Given this list of marker genes LAMP3, LSM11, SLC25A37, SOX6, CACNA2D1, RTN4, PTPN3, SLC13A3, AHCYL2, FGF2, UBFD1, NR2C2, PPP1R11, SUMO3, TBP, SLC12A2, SGK1, RPS6KA6, PTH, NAPG, PTPRD, ETNK1, RECK, ZCCHC2, TMEM245, RBM12, CHAC1, CD3E, ZNF449, MAP3K9, PISD, MTFR1L, BZW1, ARHGAP32, TGFBR3, MYLK, SYPL1, CYB561A3 (cytochrome b561 family member A3), P3H2, EPHB2, PHF19, NRBP1, PDK4, TUBA4A, SNX16, C1QL3, COL12A1, SUZ12, RAB11FIP2, LUZP1, CHPT1, ABL2, CCND2, LRIG2, YWHAH, FLT3, SSR1, SLC39A10, CCDC83, UNC13A, WNK3, SMURF2, RNF217, SPTLC1, LITAF, RAD23B, BCL11B, RORA, PAFAH1B2, HOXA10, PDE3B, KIF5B, PLRG1, ZC2HC1A, MYEF2, EYA1, FAM110C, ATXN7L3B, MAP7, SLC2A3, FAM81A, FAM91A1, RASGEF1B, PPM1E, EZH1, SKI, MAN2A2, FAM133B, ANKS1A, KIF5C, USP25 (ubiquitin specific peptidase 25), C2orf72, MIDEAS, TCAIM, CMC4, KIF3B, PTPN4, OMG, SIRT4, KRTAP4-6, CDC37L1, AVL9, IPO7, RNF144B, DMPK, LAMC1, LRP6 (LDL receptor related protein 6), GAREM1, APLN, RBM24, FASN, DLL1, HELZ, ARHGDIA, YRDC, DENND2C, LRP2, SIK1, ABHD2, PTCH1, RNF10, PAPPA, FBXW7, SYNRG, SPRED1, FAM135A, ARMH4, PELI2, DNAJB4, G0S2, COPS7B, CD80, PPP6R3, ZCCHC3, SAMD10, PIK3R1 (NCBI Gene Id 5295), SEMA6D, SLC11A2, SCN8A, SNTB2, SH3GL2, GRM7, SOBP, SERBP1, PLEKHA1, DIXDC1, CACNA1E, TFAP2A, CAPZA2, DNAJA2 (DnaJ heat shock protein family (Hsp40) member A2), PCMT1, NOB1, KCNK10, ARFGAP2, FBXL20, BTAF1, LATS1, CPEB3, MYO5A, CBX4, UBR3, IKBKB, KIF21A, CUX1, CC2D1B, KCNJ2 (potassium inwardly rectifying channel subfamily J member 2), UBQLNL, NUP50, ARL2, TRAM1, SMIM13, MIB1, ADAMTS3, CDHR1, ROCK2, ZFHX3, SLC6A11, SHOC2, SAV1 (salvador family WW domain containing protein 1), LARGE2, NOS1, EXOC3L2, LGR5, ARL3, WNT7A, SSTR3, PRKAR2A, CCDC88C, AXIN2, FNTA, NCS1, SPAG7, CD47, TENM2, ILDR2, ATXN1L, MYB, CDC25A, CDK8, NAA25 (N-alpha-acetyltransferase 25, NatB auxiliary subunit), CPSF7, NSG1, COP1, SYDE2, AGO4, PDIA6, RPS6KA3, CDK17, CDC27, DYRK1B, KANK1, SEMA3D, MEX3C, CPEB2, FBXO21, SPTBN2, DCLK1, MEOX2, PLXNA4, VEGFA, IVNS1ABP, ABCF3, PIAS2, MGAT4A, GLS2, CDC42SE2, CPD, RARB, C2orf42, GPN1, TTC14, ARIH1, CYP2S1, FGF7, SLC15A4, MYBL1, STXBP3, CACUL1, ENSG00000275993, OGT, PCDH17, CHUK, LRRN3, CXCR5 (NCBI Gene Id 643), GABARAPL1, ZBTB46, RIMKLB, ATXN7L2, ZC3H13, DENND1B, MNT, PCDH9, COBLL1, FGFR1, TMEM268, CFAP45, AMOT, RAB9B, RICTOR, IL7R, PEX13, USP31, USP3, WBP11, ARPP19, PPP2R1B, WEE1, DLEU7, SREK1, SEMA5B, TMC7 (transmembrane channel like 7), ACSL4, DPY19L4, DCP1A, NRP2, ATF6, ZNF367, HSPG2, TSC22D2, PABIR2, MOV10, RBPJ, C12orf76 (NCBI Gene Id 400073), CCNE1, MAMSTR, ATG13, ACVR2A, KDSR, JARID2, NSMF, CSRNP1, MKNK1, ELL, PDZD8, RIF1, TBPL1, SLC2A14, CARM1, RUNDC3B, LURAP1L, HSPA4L, RAB9A, RET, DENND4A, G2E3, SALL4, NAV1, SEMA3A, CLOCK, HECTD4, AMOTL1, CCDC6, GATAD2A, CREBRF, WIPI2, SIPA1L2 (signal induced proliferation associated 1 like 2), ATXN7L1, CHD2, RUNX1T1, EGLN1, ISM2, STXBP5, HECTD1, KRTAP11-1, VPS33B, USP15, ZNRF2, TMEM178B, ACOX1, RAB30, NECTIN1 (nectin cell adhesion molecule 1), HMBOX1, SLC36A1, MOB3B, MKX, MIGA1, AREL1, DRD1, USP44, HERC6, ZBTB34, WNT3A, RASEF, CHIC1, TRIM66, NRN1, STK33, TMEM100, RETREG2, SEPTIN2, RGMA, PTPRR, HMGA1, ENAH, ISLR, SLIT2, ZSCAN31, RAD50, ACVR2B, ARHGAP20, SYNJ1, ANO3, FOXK1 (NCBI Gene Id 650798), HIGD1A, UNC5D, ZDHHC15, GCC2, AGO1, EPB41L4B, NHLRC2, CBX2, SESN1, MBNL2, CAPRIN1, HTR2A, IPPK, EXT2, ASH1L, SLC35G1, STRADB, ATXN2, UBE4B, SEL1L3, SESTD1, IHH, CNOT6L, AK4, RS1, PNPLA6, GALNT7, UBE2Q1, PARVA, NF1, WNT4, OTX1, SNRPB2, FAM89A, TLL1, UNC80, ZFHX4, ADGRL1, MTMR3, POU2F1 (POU class 2 homeobox 1), AMMECR1, GSTCD, MFN2, TMCC1, BAG4, DESI1, HIPK2, TMEM154, AKT3, ADAMTS6, ANKRD46, CLCN4 (NCBI Gene Id 4412), MYO5B, PLAG1, SUCO, SEH1L, SPRYD3, ZBTB39, TGIF2, DEPDC4, GPATCH8, CBX6, CLUH, RREB1, BTG2, SOCS6, ZMAT3, XPO7, PLPP1, GOLGA1, CEP85L, TMEM135, BTRC, MAP2K1 (NCBI Gene Id 5604), LRRK1, DDX3Y, VTI1B, TFCP2L1, SLC4A4, PRDM4, IGF1R (NCBI Gene Id 51049), PRRC2C, CMPK1, TNFSF13B, ATXN7L3, STOX2, YTHDC1, USP42, UROS, FGF9, RELN (NCBI Gene Id 5649), UBE4A, SYT4, TMEM183A, DDX3X (DEAD-box helicase 3 X-linked), PIP4P2, SRPRA, N4BP1, RSPO3, CASK, SLC9A6, MCU, CDK5R1, GFAP, CDCA4, ZMYM2, SALL1, RFK, JPH3, ANXA11, CHEK1, MAP3K13, ZBTB20, MED26, INSR, KCTD8, CCNJL, GHR, NUFIP2, QKI, ARMCX2 (NCBI Gene Id 9823), MASP1, CEP55, ANLN, SMURF1, SALL3, TBL1XR1, GPR63, KPNA3, UBN2, E2F3, KIF1B, SEC24A, SMAD7, IARS1, RFX3, PEDS1-UBE2V1, PAG1, TMEM74B, TARBP2, LYPLA2 (lysophospholipase 2), SYT3, EPC1, PPM1A, ELMOD1, RASSF8, DMTF1, ELL2, EPHA7, ATG14, TRANK1, DYNC1LI2 (dynein cytoplasmic 1 light intermediate chain 2), RBM6, ZNF548, ZNF622, PAFAH1B1, TAB3, BMPR1A, SCOC, ST8SIA3, UBE2V1, PIP4P1, RSBN1, TRABD2B, GALNT13, CYP26B1, ATG9A, FERMT2, KLHL2, RBBP6, ZBTB44, CSDE1, RTN3, CD2AP, ARHGAP12, LDLRAD2, CCND1, IGF2R, SLC20A2, SON (SON DNA and RNA binding protein), ZNRF3, HEPHL1, PLXNC1, GNAT1, C1orf21, ADRB2, TNRC6B, EDA, ZNF691, MYRIP, AMER1, PPT2, TLK1, UTP25, ACTR2, SETD3, KIF23, CLDN12, OOEP, IFT74, KCNN4, WWC1, ELAC1, HTR4, GGA3, SVIP, ZNHIT6, ST7L, ANKUB1, BCL2L2, VPS4A, MOB4, LRIG1, KCNG4, TMEM199, NFATC3, CASR, CCNT1, here is a description of the gene set: Human Gene Set: MIR195_5P from publication Chen Y, Wang X (PMID 31504780) studied in species Homo sapiens Genes predicted to be targets of miRBase v22 microRNA hsa-miR-195-5p in miRDB v6.0 with MirTarget v4 prediction scores > 80 (high confidence targets).